The following is a description of a gene set: Any process involved in the maturation of a precursor 5.8S ribosomal RNA (rRNA) molecule into a mature 5.8S rRNA molecule. studied in species Homo sapiens Human Gene Set: GOBP_MATURATION_OF_5_8S_RRNA, and this is the list of marker genes: RPF1, RRS1, MAK16, EXOSC4, ABT1, URB1 (NCBI Gene Id 9875), PES1, EXOSC7, ERI1, MTREX, NOL9, RPP40, RRP15, NSA2 (NCBI Gene Id 10412), EXOSC3, FCF1, EIF6, RPS21, PRKDC, EXOSC8, EXOSC10, NOP14, MPHOSPH6, C1D, WDR12, LAS1L, RCL1, BOP1, KRI1, NOP9 (NOP9 nucleolar protein), EXOSC2, EXOSC9, UTP20, FTSJ3